The following is a description of a gene set: The process whose specific outcome is the progression of an extraembryonic membrane over time, from its formation to the mature structure. species: Mus musculus Mouse Gene Set: GOBP_EXTRAEMBRYONIC_MEMBRANE_DEVELOPMENT, and this is the list of marker genes: Bmp7, Taf10, Htra1, Ascl2 (achaete-scute family bHLH transcription factor 2), E2f7, Dnmt3l, Paxip1, Pagr1a, Dnajb6, Map3k4, E2f8, Bmp5, Fzd5, Tmed2